The following is a description of a gene set: studied in species Homo sapiens Human Gene Set: GOMF_NUCLEAR_LOCALIZATION_SEQUENCE_BINDING Binding to a nuclear localization sequence, a specific peptide sequence that acts as a signal to localize the protein within the nucleus., and this is the list of marker genes: KPNA5, NUP214 (nucleoporin 214), NUP153, BRAP, TNPO1, POM121B, POM121, TNPO2, POM121C, IPO5, KPNB1, IPO4, KPNA3, KPNA2, NPAP1, POM121L2, KPNA7, RANBP6, CABP1, NUP58, NUP98, NFKBIA (NCBI Gene Id 4792), KPNA6, KPNA1, KPNA4